Given this list of marker genes RNF213, SFPQ, GSK3A, MAPK1, TRIM27, CTSG, MAPK3, here is a description of the gene set: Human Gene Set: REACTOME_SUPPRESSION_OF_APOPTOSIS studied in species Homo sapiens Suppression of apoptosis